Given this list of marker genes Kif13a, Vamp5, Gga2, Acsl3, Pkdcc, Ank3, Blzf1, Vamp2, Rab26, Cln3 (CLN3 lysosomal/endosomal transmembrane protein, battenin), Arfrp1, Sys1, Macf1, Lypla1, Nsf, Bbs2, Cnst, Golga7, Golph3l, Rab11fip3, Krt18, Gga3, Vamp3 (vesicle-associated membrane protein 3), Rab34 (NCBI Gene Id 19376), Rab10, Gga1, Phaf1, Atp2c1, Lyplal1, Bbs1, Rack1, Golga4, Amn, Rab31, Sptbn1, Csk, Optn, Prepl, Golph3, Vamp4, here is a description of the gene set: The directed movement of proteins from the Golgi to the plasma membrane in transport vesicles that move from the trans-Golgi network to the plasma membrane. species: Mus musculus Mouse Gene Set: GOBP_GOLGI_TO_PLASMA_MEMBRANE_PROTEIN_TRANSPORT